Given this list of marker genes LENG1, LINC-PINT, CDKN2A, FERMT2, STK4, RAB29, SERPINA1, XAF1, BET1, GPR157 (G protein-coupled receptor 157), IFITM1, PI4K2B, MAGT1, CD274, RAB8B, NUB1, PHF11, TRPC4AP, OSTC, ADA, SEC61G, HERC6, LINC00635, ILF2, PSMA6, NAV1, ZNF280C, C3orf38, GNL3, SWAP70, CNKSR3, FNDC3A, PPA1, DYNLT1, GPR137B, FSD1L, PLXNC1, KDELR2, ZRANB2, SAMD9, NCK2, ZNF8, LDLRAD3, BACH2, LINC01181, SIK1, SPAG9, TFPI2, RFWD3, ZNF221, CD70, CAMK1G, NRG4, RFTN1, LAD1, CYRIA, VCAN, FABP3, TNFSF15, RBBP5, LRIF1, RRN3, CCL20, CDYL, TMED2, BIRC3, TMEM277P, NGDN, LILRB4, EPB41L3, IL15RA, MORF4L2, CLDN16, ZNRF1 (NCBI Gene Id 84937), PLA2G4A, GOLT1B, DDX60L, FPR2, IRX5, ODF4, ITGB8, TAP2, WASL, BCL2, PCDH9, TMEM41A, C15orf48, RBM7, SURF6, PPFIBP2, MAML2, BLVRA, HES4, MSC-AS1 (MSC antisense RNA 1), CRACD, CD48, LINC01619, ARHGAP22, GRB10, SAR1A, PDGFA, TLCD3A, RAB21, LINC02381, IL12B, DUSP4, FXYD6, SOCS2, CRLF2, PARP9, BTN3A3, PGM3, FUBP1, PRKCZ, HAPLN3, ANKRD22, SOD2, SELENOK, MMP7, TARP, BTG1, SNHG15, ABTB2, RIT1, CD200, PCID2, MT1X, EBI3, DDX60, STAT4, DNAJA1, C5orf15, SCHIP1, UGP2, ADIRF, ALG2, MT2A, TRAFD1, TXN, SLAMF7, BCL2L14, TIAM2, SP110, AK4, ZNF253, IRF9, HSD11B1, IL12A, ISG15, ACOT9, LAMP3, CHAC1, BATF, WDR33, MSANTD2 (NCBI Gene Id 79684), IFITM3, FRMD3, ZNF281 (zinc finger protein 281), ARPC1A, COBLL1, PSMA2, C17orf58, IL15, KCTD21, POLR1F, IFI27, CD38, STEAP1, CASP7, KYNU, ADGRB2, MET, STEAP1B, PSME2, ENTHD1, DHX58, POLR2D, CSF2, EMP3, PHF13, TVP23B, ZNF701, MAPKBP1, DEPDC7, KIF2A, GUCY1B1, XRN1, SLC38A4-AS1, CXCR5, AK8, LILRA3, APOL6, TNFAIP6, PERP, SYNM, UPB1, MMAA, TRPA1, DESI1 (NCBI Gene Id 91610), here is a description of the gene set: from publication Napolitani G, Rinaldi A, Bertoni F, Sallusto F, Lanzavecchia A (PMID 15995707) Toll like receptors (TLRs) sense microbial products and initiate adaptive immune responses by activating dendritic cells (DCs). Since pathogens may contain several agonists we asked whether different TLRs may synergize in DC activation. We report that in human and mouse DC TLR3 or TLR4 potently synergize with TLR7, TLR8 or TLR9 in the induction of selected cytokine genes. Upon synergistic stimulation, IL-12, IL-23 and Delta-4 are induced at levels 50-100 fold higher than those induced by optimal concentrations of single agonists, leading to enhanced and sustained TH1 polarizing capacity. Using microarray analysis we show that only 1.5% of the transcripts induced by single TLR agonists are synergistically regulated by combinations of TLR4 and TLR8 agonists. These results identify a combinatorial code by which DCs discriminate pathogens and provide (suggest) a rationale to design adjuvants for TH1 responses. Series_overall_design: 3 untreated, 3 treated with LPS at 2h, 3 treated with LPS at 8h, 3 treated with R848 at 2h, 3 treated with R848 at 8h, 3 treated with LPS + R848 at 2h, 3 treated with LPS + R848 at 8h Human Gene Set: GSE2706_2H_VS_8H_R848_AND_LPS_STIM_DC_DN Genes down-regulated in comparison of dendritic cells (DC) stimulated with R848 at 2 h versus DCs stimulated with LPS (TLR4 agonist) at 8 h. studied in species Homo sapiens